Given this list of marker genes CDKN2C, CDKN2B, CDKN1A, SDHD, MEN1, CDKN1B, here is a description of the gene set: studied in species Homo sapiens Human Gene Set: HP_INTESTINAL_CARCINOID Intestinal carcinoid